Given this list of marker genes LILRB4, KIR2DL1, KLRC1, LYN, HLA-G, IL20RB (interleukin 20 receptor subunit beta), LILRB1, PSG9, CD33, CLEC12B, LILRB2, here is a description of the gene set: Human Gene Set: GOBP_IMMUNE_RESPONSE_INHIBITING_SIGNAL_TRANSDUCTION studied in species Homo sapiens The cascade of processes by which a signal interacts with a receptor, causing a change in the level or activity of a second messenger or other downstream target, and ultimately leading to inhibition of an immune response.